Given this list of marker genes IKZF2, EPC2, HCAR3, ALS2, S100P, FAM117A, TEX30, CXCR1, PBXIP1, PDE3B, SLC18A2, CR1, UBA6-DT, ADAM19, IFITM1, SH3BP5L, RAB3D, MCTP2, TMEM154, TTC39B, AKAP12 (A-kinase anchoring protein 12), MMP25, KIF13A, CCR3 (C-C motif chemokine receptor 3), FGFR1, OLIG1, ORMDL3, ETS1, TTN, CA8, PABIR3, IL32, CD244, RAB37, CCHCR1, ADAM8, HPGD, PRSS57, BCL9L, PIM1, STAP1, CSF2RB, HELB, SLC45A3, KLF5, RAB27A, ATP2A3, REXO5, LINC00324, RAB44, NMT2, FRY, TESPA1, ELL2 (NCBI Gene Id 22936), OXER1, RCAN3, SPMIP5, MIR222HG, NLRC3, RHEX (NCBI Gene Id 440712), MHENCR, C16orf54, TEC, CD69, LIMK2, CPA3, TOP1MT, KIF21B, SERPINB2, ANKRD28, RFLNB, PHLDA2, EIF4E3, ZNF683, CSF1, ELP1 (elongator acetyltransferase complex subunit 1), TNIK, CCNA1, PKP2, MXD3, PADI4, GATA2, CLC, SPTBN1, RGL4, IL5RA, EIF2AK3, HDC, ATP10D, WIPI1, JAZF1, MS4A3, HS6ST1, VSTM1, TRAF3IP2 (NCBI Gene Id 25997), LAX1, ZNF429, LAT, GATA1, HK3, CD9, ITGA2B, IL4, MYB, GCSAML, IL1RL1, NOTCH1 (notch receptor 1), LFNG, ADGRG3, APOBEC3A, HYPK, PIGA, ENTPD7, here is a description of the gene set: Human Gene Set: HE_LIM_SUN_FETAL_LUNG_C2_BASOPHIL_CELL Basophil from publication He P, Lim K, Sun D, Pett JP, Jeng Q, Polanski K, Dong Z, Bolt L, Richardson L, Mamanova L, Dabrowska M, Wilbrey-Clark A, Madissoon E, Tuong ZK, Dann E, Suo C, Goh I, Yoshida M, Nikolić MZ, Janes SM, He X, Barker RA, Teichmann SA, Marioni JC, Meyer KB, Rawlins EL (PMID 36493756) studied in species Homo sapiens